The following is a description of a gene set: Mouse Gene Set: GOBP_PROTEIN_KINASE_C_SIGNALING species: Mus musculus A series of reactions, mediated by the intracellular serine/threonine kinase protein kinase C, which occurs as a result of a single trigger reaction or compound., and this is the list of marker genes: Phlpp1, Akap12, Prkcz, Adgrg1, Coro1b (coronin, actin binding protein 1B), Slc26a6, Prkcb, Prkch, Prss33, Flt4, Pla2g6, Cd40, Mas1 (NCBI Gene Id 17171), Wnt5a, Avp, Dgkq, Gpd1l, Adra1a, Wnt11, Htr2b, Arpc2, Myadm, Vegfa, Flot1, Pdgfb